The following is a description of a gene set: species: Homo sapiens Human Gene Set: GOBP_INTRACELLULAR_RECEPTOR_SIGNALING_PATHWAY The series of molecular signals initiated by a ligand binding to a receptor located within a cell., and this is the list of marker genes: NPLOC4, DDX54, ERRFI1, STRN3, SFRP1, HCFC2, NLRX1, SNW1, COLEC12, ZDHHC7, DEFA3, CYP26B1, ALOX15B, CYP26A1, HMGB1, AARS2, PTF1A, PER1, CNOT1, TLR3, CYP27B1, ALOXE3, SKP2, PRKDC, VDR, PDE3A, NCOA3, NCOA4 (NCBI Gene Id 8031), MYD88, HNF4A, RORA, RIOK3 (RIO kinase 3), NOD1, LSM14A, SLC19A1, FBXL2, ERBIN, FOXP1, LACC1, PYDC2 (pyrin domain containing 2), RNF39, NR6A1, PADI2, THRB, NR2E3, ISL1, DDX3X, KCNJ8, SCGB2A2 (NCBI Gene Id 5661), PGR, PIK3AP1, TICAM1, ACTN4, KANK2, TRAF3IP3, FLOT2, PTPRS, LAMP2, DDX41, PIM1, PRAME, VPS18 (VPS18 core subunit of CORVET and HOPS complexes), WBP2, NLRP6, DDX60, NR1I2, ZDHHC5 (zinc finger DHHC-type palmitoyltransferase 5), RNF6, MED1, TRIM65, PAQR7, SIRT1, ZDHHC18, PARK7, ZC3HAV1, DHX58, TIFA, RNF34, CNOT2, PELI1, TLR4, MN1, PUM1, ESR2, SNAI2, NCOA1, MIR27B, MAVS, NCOR2, NR2C2, IGF1, ZCCHC3, HDAC1, MIR4691, DEFA1B, WASHC4, RXRG, RARG, TRIM31, TARBP2, KDM1A, HSPA1A, KDM5D, LMO3, NR5A2, HSPA8, RHOXF1, NR2F1, RNF14, TASL, ZDHHC9, GBP5, P2RX7, SIRT2, LEP, RIGI, MAP3K7, ATAT1, THRA, SREBF1, ZBTB7A, DDRGK1, GHRHR, GRAMD4, BMP2, FABP5, ANKRD17, CYP24A1, FCRL3, HAVCR2, IFIH1, MIR708, NR2E1, PKN1, NR1H2, TRERF1, NCOR1, RWDD1, TAB1, UBQLN1 (NCBI Gene Id 54347), RSAD2, CST11, CPTP, PML, ALOX15, HDAC2, ELP6, SHQ1, CCDC62, PPP5C, IRF5, ASXL1 (NCBI Gene Id 23393), ABHD17A, CREBRF, NR1D2, ARNT, OGT, TCF21, ZNRF4, OAS1, CSNK1A1, DAXX, LYPLAL1, KLF2, ZMIZ1, PPARG, TRIM24, ESRRA, IRF7, JUND, HSPA1B, AKR1C3, NR1D1, XIAP, ESR1, NR1H4, EPG5, PAQR8, TRIM16, NLRC3, RHOA, DNAAF4, RORC, PPARA, OASL, OR51E2, TNF, PRKD1, TREML4, NEDD4, FAM120B, C1QBP, ASXL2, DDX17, USP17L2, IRAK4, PPT1, CLOCK, MEFV, TSPAN6, OTULIN, RAB7B, TRIM3, CARM1, UBR5, SRARP, TMF1, RORB, IKBKB, UFL1, SCGB2A1, AKT1, DAB2, SAFB2, TBK1, TLR6, AHR, PYDC5, PPARGC1B, DHX33, PYDC1, CAV1, CRY1, USP15, VPS11, IRAK1, TRIM15, UFSP2, PRMT2, CYP7B1, EGLN2, PHB1, PLIN5, SRC, FOXA1, SP100, BECN1, PMEPA1, GPHB5, NOD2, LATS2, DEFA1, PHB2, GPER1, NFKBIA, STAT3, NR2F2, USP26, BRCC3, TAX1BP1, BMAL1, TRIP4, PGRMC2 (progesterone receptor membrane component 2), KDM3A, HDAC6, ZNF366, TAF7, ZNF536, RIPK2, TRIM11, PLCG2, JAK2, IRGM, GKN2, RBFOX2, BANF1, LATS1, NR2C1, CD36, RELA, AHRR, MARK4, NEK7, IFI16, HUWE1, GBP2 (guanylate binding protein 2), IPO5, DDX5, SLC15A3, PAQR3, PTPN22, F2RL1, NR1H3, TRIM68, ZDHHC3, SLC46A2, RNF135, LBH, NAGK, MIR34A, TNIP2, EZH2, MIR208A, PLPP1, NLRP2B, SCIMP, TREX1, STUB1, DHRS3 (dehydrogenase/reductase 3), RXRB, CITED2, CALR, ABHD8, PPP2CA, NR4A2, TNFAIP3, BIRC3, PCBP2, HNF4G, CYLD, NCOA2, SEC14L1 (NCBI Gene Id 6397), WDFY1, UFD1, TADA3, NR3C2, AR, USP50, PTGIS, UBA5, TLR8, HMGA2 (high mobility group AT-hook 2), OAS3, MAPK8, CGAS, LILRA4, AURKB, NR1I3, UBE3A, SCARA3, GREB1L, TCF7L2, NR2F6, HEYL, NR0B1, MARCHF5, POU4F2, TLR7, KCNK13, PARP1, ESRRG (NCBI Gene Id 2104), SMPDL3A, CYP26C1, TRAF6, SAFB, CRKL, BTK, EIF2AK2, TP63, SLC15A2, RNF170, KCNK6, KMT2D, GPATCH3, PAK1, PIAS2 (protein inhibitor of activated STAT 2), SMARCA4, GPS2, EP300, NR5A1, MIR613, FKBP4, RTN4, ALPK1, PAGR1, RNF125, TAF1, CTBP2, ABHD2, NODAL, STING1, ZDHHC1, CLPB, PRCP, MAP2K6, RARB (retinoic acid receptor beta), PLA2G10, ITCH, DCBLD2, NLRP1, CRY2, TIRAP, PDK3, YWHAH, FLOT1, ZDHHC12, PPP6C, NOP53, NLRP3, ESRRB, CDK12, IRF3, UFM1, TLR9, TGIF1, SLC15A4, YWHAE, ALDH1A2, RARA, PPARD, BIRC2, STMP1, TREM2, GPRIN3, TRIM25, FOXH1, TWIST1, NR3C1, INAVA, PYCARD, KDM4C (lysine demethylase 4C), CARD8, TKFC, RXRA, BRCA1, NKX3-1, SPSB3, NR4A3, TBX1, UNC93B1, PUM2, FSHR, NR4A1, CNOT9, RFTN1, CALCOCO1